Given this list of marker genes Pcyt2, Cept1, Lpin3, Etnk2, Chka, Phospho1, Etnppl (NCBI Gene Id 99567), Selenoi, Chkb, Lpin2, Etnk1, here is a description of the gene set: Mouse Gene Set: REACTOME_SYNTHESIS_OF_PE Synthesis of PE species: Mus musculus